The following is a description of a gene set: We have previously demonstrated that c-Myc impairs p53-mediated apoptosis in K562 human leukemia cells, which lack ARF. To investigate the mechanisms by which c-Myc protects from p53-mediated apoptosis, we used K562 cells that conditionally express c-Myc and harbor a temperature-sensitive allele of p53. Gene expression profiles of cells expressing wild-type conformation p53 in the presence of either uninduced or induced c-Myc were analysed by cDNA microarrays. The results show that multiple p53 target genes are downregulated when c-Myc is present, including p21WAF1, MDM2, PERP, NOXA, GADD45, DDB2, PIR121 and p53R2. Also, a number of genes that are upregulated by c-Myc in cells expressing wild-type conformation p53 encode chaperones related to cell death protection as HSP105, HSP90 and HSP27. Both downregulation of p53 target genes and upregulation of chaperones could explain the inhibition of apoptosis observed in K562 cells with ectopic c-Myc. Myc-mediated impairment of p53 transactivation was not restricted to K562 cells, but it was reproduced in a panel of human cancer cell lines derived from different tissues. Our data suggest that elevated levels of Myc counteract p53 activity in human tumor cells that lack ARF. This mechanism could contribute to explain the c-Myc deregulation frequently found in cancer. from publication Ceballos E, Muñoz-Alonso MJ, Berwanger B, Acosta JC, Hernández R, Krause M, Hartmann O, Eilers M, León J (PMID 15856024) Human Gene Set: CEBALLOS_TARGETS_OF_TP53_AND_MYC_UP studied in species Homo sapiens Genes up-regulated in K562 cells (chronic myelogenous leukemia, CML) expressing TP53 and MYC., and this is the list of marker genes: STAT5B, HSPA2, INSIG1, JUNB, ACSL1, MYC, HSPH1, PFKFB1, NEK3, CD55, MTHFD2, ZNF532, ACSL3, UAP1, SRSF7, PDIA3, CTH, DRG1, ISLR